Given this list of marker genes CPEB1, PAF1, PCF11, CSTF3, LSM11, CPSF2, TUT1, CDK9, DHX36, CLP1, YTHDC1, TENT4B, CSTF2, ZFP36L1, BARD1, WDR33, ZC3H3, CPSF7, SSU72, PAPOLA, CPSF6, CPSF3, RPRD2, LSM10, NCBP2, ZCCHC8, CCNB1, CDC73, AHCYL1, ANGEL2, TENT2, RPRD1A, RPRD1B, ZNF473, LEO1, SLBP, MBLAC1, NUDT21, CSTF1, NCBP1, CSTF2T, here is a description of the gene set: Human Gene Set: GOBP_MRNA_3_END_PROCESSING Any process involved in forming the mature 3' end of an mRNA molecule. species: Homo sapiens